Given this list of marker genes HCN3, HCN4, KCNJ18, CLCN1, HCN2, CACNA1F, CACNG5, TRPA1, ABCC8, KCNH5, KCNA6, KCNA5 (NCBI Gene Id 3741), CACNG2, ABCC9, KCNK3 (NCBI Gene Id 3777), KCNJ14, ANO6, LRRC38, KCNH1, KCNG2, CACNB3, GRIN2B, TPCN1, KCNQ3, OPRM1, KCNAB1, VDAC1, CACNG3, KCNK13, CLCNKA, RYR1, KCNA7, KCNJ16, TMC4, CACNG8, CALHM3, KCNC2, LRRC26, KCNE2, CACNA1G, KCNK7, TMEM266, KCNA3, KCNJ8, KCNB2, CALHM6, CACNG7, SLC17A3, KCNJ9, CACNA2D2, CACNA2D1, KCNC4, SNAP25, PKD2, KCNE1, CACNB4, CACNA1C, CACNA1E, KCNJ13, NCS1, CAV1, KCNJ12, KCNIP2, TSPOAP1, KCNK6, KCNE5, KCNK18, ANO1, KCNJ4, CATSPER2, CALHM1, GRIN2C, KCNK10, TRPV1, KCNK1, CLCNKB, KCNJ3, KCNMB4, TPCN2, KCNA4, KCNA10, KCNN3, KCNG1, KCNS2, SCN1A, CACNA1H, KCNK12, KCNK17, CACHD1, KCNQ4, P2RX5, KCNMA1, CACNA2D4, KCNH2, CACNA1B, KCNJ6, GRIN2D, KCNJ1, KCNJ15, GRIN3A, KCNH3, CACNA1I, KCNQ2, CACNB2 (calcium voltage-gated channel auxiliary subunit beta 2), CLCN4, KCNH8, KCNS3, KCNE4, CACNB1, TMC1, KCNA2, CYBB, CATSPER3, TMEM37, CACNA1A, KCNK4, SCN10A, KCNAB2 (NCBI Gene Id 8514), KCND1, KCNK5, KCNH4, KCNB1 (NCBI Gene Id 3745), GRIN1, KCND2, CLCN6, KCNJ11 (NCBI Gene Id 3767), KCNC3, VDAC3, SCN2B, CACNA1D, KCNA1, TMC2, LRRC55, KCNK9, HCN1, KCNK2, KCNH6, VDAC2, KCNC1, LRRC52 (NCBI Gene Id 440699), KCNV2, CATSPER1, GPR89B, KCNN2, KCNH7, CACNG1, KCNJ2, CLCN2, KCNQ5, KCNK15, GRIN2A, GPR89A, CACNA2D3, CACNA1S, KCNE3, KCNT2 (NCBI Gene Id 343450), KCNS1, KCNJ5, TMEM109, CLCN5, KCNJ10, KCNK16, CLCN3, CACNG4, CATSPER4, KCNF1, GRIN3B, KCNN1, KCNAB3, KCNG3 (potassium voltage-gated channel modifier subfamily G member 3), KCNG4, KCNV1, ITGAV, CACNG6, HVCN1 (NCBI Gene Id 84329), KCNT1, KCNQ1, KCND3, here is a description of the gene set: Human Gene Set: GOMF_VOLTAGE_GATED_CHANNEL_ACTIVITY Enables the transmembrane transfer of a solute by a channel whose open state is dependent on the voltage across the membrane in which it is embedded. species: Homo sapiens